The following is a description of a gene set: species: Mus musculus Binding to phosphatidylinositol-3,4,5-trisphosphate, a derivative of phosphatidylinositol in which the inositol ring is phosphorylated at the 3', 4' and 5' positions. Mouse Gene Set: GOMF_PHOSPHATIDYLINOSITOL_3_4_5_TRISPHOSPHATE_BINDING, and this is the list of marker genes: Fundc2b, Arap2, Myo1b, Pirt, Plekhb2, Arap3, Inppl1, Jph2, Ogt, Asap1, Kif16b, Btk, Hcn1, Washc2 (NCBI Gene Id 68154), Cyth3, Adap1, Dnm1, Adap2, Zfyve1, Rs1, Npm1, Commd1, Nrgn, Zfyve16, Myo1g, Hip1r, Pard3, Gbf1 (golgi-specific brefeldin A-resistance factor 1), Fchsd2, Mapkap1, Pla2g4e, Iqgap1 (NCBI Gene Id 52178), Arhgap9, Myo10, Iqgap2, Fundc2, Fermt2, Racgap1, Arap1, Phlda3, Rag2, Gab2, Anxa8, Akt1, Irgm1, Obscn, Dapp1